The following is a description of a gene set: Non-compact myelin located adjacent to the nodes of Ranvier in a myelin segment. These non-compact regions include cytoplasm from the cell responsible for synthesizing the myelin. Lateral loops are found in the paranodal region adjacent to the nodes of Ranvier, while Schmidt-Lantermann clefts are analogous structures found within the compact myelin internode. Mouse Gene Set: GOCC_LATERAL_LOOP studied in species Mus musculus, and this is the list of marker genes: Pard3, Cdh1, Erbb2, Dlg1, Stx4a, Pals1, Sirt2